Given this list of marker genes RBX1, NDUFB2, CXCL9, NDUFB7, BRI3, CALM3, MICOS13, IFI27L2, MRPL51, TIMM8B, S100A8, ISG15, COX7B (cytochrome c oxidase subunit 7B), CHCHD10, DUSP23, HSPE1, S100A9, GADD45GIP1, DAB2, ATP5F1EP2, VAMP5, HAMP, UQCRQ, HCST, CCL2, NICOL1, BLVRB, RPS21, NDUFS6, PSME2, MRPL41, SLIRP, TXNDC17, FABP5, ATP5ME, RPL38, UQCC2, TXN, DNPH1, RPS29, CTSZ, HMOX1, RNASE1, COPS9, ATP5MF, NDUFA3, POLR2L, COX6C, ATOX1, STAB1, here is a description of the gene set: Human Gene Set: GAVISH_3CA_METAPROGRAM_MACROPHAGES_RESPIRATION Genes upregulated in subsets of cells of a given type within various tumors studied in species Homo sapiens from publication Gavish A, Tyler M, Greenwald AC, Hoefflin R, Simkin D, Tschernichovsky R, Galili Darnell N, Somech E, Barbolin C, Antman T, Kovarsky D, Barrett T, Gonzalez Castro LN, Halder D, Chanoch-Myers R, Laffy J, Mints M, Wider A, Tal R, Spitzer A, Hara T, Raitses-Gurevich M, Stossel C, Golan T, Tirosh A, Suvà ML, Puram SV, Tirosh I (PMID 37258682) In this study, an extensive analysis was conducted to define meta-programs (MPs) capturing intra-tumor heterogeneity across a spectrum of tumor types. The approach utilized non-negative matrix factorization (NMF) to analyze each cell type separately within individual tumor samples. This involved the analysis of malignant cells, macrophages, fibroblasts, endothelial cells, epithelial cells, T-cells, and B-cells. NMF was executed with varying parameter values (K=4, 5, 6, 7, 8, 9), thereby generating 39 programs for each cell type per sample. Each NMF program was summarized by the top genes based on NMF coefficients.\nRobust MPs were then delineated for each cell type using a set of stringent criteria, including recurrence within the same tumor, similarity to programs in other tumors, and non-redundancy within a tumor. Subsequently, these robust NMF programs were clustered (per cell type) based on Jaccard similarity, leading to the identification of MPs associated with each cell type.\nTo enhance the quality of the MPs, a refinement steps were undertaken, involving the removal of MPs suspected of reflecting low-quality data (with an overrepresentation of ribosomal proteins or mitochondrial-encoded genes), single-study inclusion, or similarity to miss-annotated cell types.